Given this list of marker genes Sox11, Tbx1, Foxe1, Col11a2, Tshz1, here is a description of the gene set: Mouse Gene Set: GOBP_SOFT_PALATE_DEVELOPMENT species: Mus musculus The biological process whose specific outcome is the progression of the soft palate from an initial condition to its mature state. This process begins with the formation of the structure and ends with the mature structure, whatever form that may be including its natural destruction. The soft palate is the posterior portion of the palate extending from the posterior edge of the hard palate.